Given this list of marker genes SLC35C1, here is a description of the gene set: Reactome Pathway: Defective SLC35C1 causes congenital disorder of glycosylation 2C (CDG2C) The human gene SLC35C1 encodes a GDP-fucose transporter that resides on the Golgi membrane and mediates the transport of GDP-fucose into the Golgi lumen. Defects in SLC35C1 cause the congenital disorder of glycosylation type 2C (CDG2C aka leukocyte adhesion deficiency type II, LAD2), an autosomal recessive disorder characterised by moderate to severe psychomotor retardation, mild dysmorphism and impaired neutrophil motility. studied in species Homo sapiens part of: SLC transporter disorders